Given this list of marker genes PLAT, F7, KLK1, FGA, F2, PLG, F8 (coagulation factor VIII), F3, F9, KLKB1, VWF, FGG, SERPINB2 (serpin family B member 2), PLAU, SERPINF2, F5, F11, SERPINE1, F13B, F10 (NCBI Gene Id 14058), F12, FGB, here is a description of the gene set: studied in species Homo sapiens Human Gene Set: WP_BLOOD_CLOTTING_CASCADE Blood clotting cascade